Given this list of marker genes Zfp36l1, Dusp1, Nr4a1, Clk1, Tsc22d3, Pmaip1, Fos, here is a description of the gene set: Cytokines mediate cell-cell communication in the immune system and represent important therapeutic targets. A myriad of studies have highlighted their central role in immune function, yet we lack a global view of the cellular responses of each immune cell type to each cytokine. To address this gap, the authors created the Immune Dictionary, a compendium of single-cell transcriptomic profiles of more than 17 immune cell types in response to each of 86 cytokines (>1,400 cytokine-cell type combinations) in mouse lymph nodes in vivo. A cytokine-centric view of the dictionary revealed that most cytokines induce highly cell-type-specific responses. For example, the inflammatory cytokine interleukin-1β induces distinct gene programmes in almost every cell type. A cell-type-centric view of the dictionary identified more than 66 cytokine-driven cellular polarization states across immune cell types, including previously uncharacterized states such as an interleukin-18-induced polyfunctional natural killer cell state. from publication Cui A, Huang T, Li S, Ma A, Pérez JL, Sander C, Keskin DB, Wu CJ, Fraenkel E, Hacohen N (PMID 38057668) studied in species Mus musculus Genes negatively differentially expressed in cell type: cDC1 (conventional dendritic cell type 1) upon treatment with cytokine: APRIL in mouse lymph nodes in vivo. Mouse Gene Set: CUI_CDC1_APRIL_RESPONSE_DN